Given this list of marker genes OLAH, DESI1, ACAA2, ABHD10, ABHD12, HADHA, LYPLAL1, ACOT1, ABHD17B, THEM4 (NCBI Gene Id 117145), FASN, ABHD13, THEM5, ACOT13, PPT2, MBLAC2, HAGHL, PNKD, ABCD2, LYPLA2, ACOT4, ACOT12, PTPRT, ACOT11, BAAT, ABHD17A, ACOT7, CLN5, CPT1C, ENSG00000293349, DESI2, LYPLA1, HIBCH, ABCD1, ACOT8, ACOT9, PPT1, ACOT2, ESD, ABCD3, PLA2G6, HAGH, ACSBG2, ABHD17C, ACOT6, here is a description of the gene set: Human Gene Set: GOMF_THIOLESTER_HYDROLASE_ACTIVITY species: Homo sapiens Catalysis of the reaction: RCO-SR' + H2O = RCOOH + HSR'. This reaction is the hydrolysis of a thiolester bond, an ester formed from a carboxylic acid and a thiol (i.e., RCO-SR'), such as that found in acetyl-coenzyme A.